The following is a description of a gene set: Neighborhood of LMO1 LIM domain only 1 (rhombotin 1) in the MORF expression compendium studied in species Homo sapiens Human Gene Set: MORF_LMO1 Neighborhood of LMO1, and this is the list of marker genes: KRT33A, PIGR, CBARP, GRIP2, FOSL1, SEZ6L, GGT5 (NCBI Gene Id 2687), MT4, GRIK5, PRELID3A, EFNA2, FDXR, BCL2, KANK2, SLC16A5, SLC6A9, ITIH4, SLC30A3, PARVB (parvin beta), MOK, PAX8, DPT, CMA1, SLC2A1, NEURL1, CYP11A1, LBP, TMEM94, NCKIPSD, ZNF500, NTPCR, AQP5, WDR62, FUT6, PAX9, COLQ, SPEF1, HTR4, ARSL (arylsulfatase L), SLC4A3 (NCBI Gene Id 7858), TNFRSF25, AMFR, IRF2BP1, IMPA1, HTR1B, RBBP8, DAPK2, MC2R, HTR7, SLC24A1, JRK, LMO1